Given this list of marker genes MRPL40, CAAP1, MPZL3, RFC4, HERC1, RBM18, MARK3, ATG5, SPINK2, TMEM179B (NCBI Gene Id 374395), WASHC4, CHRD, KAT5, HIRA, ZER1, SYNCRIP, HIP1, CANX, MSANTD2, ITPKC, ANKS1A, ZBTB11, BZW1, BTAF1, GRWD1, DIABLO, ELK4, HSPD1, PTRH2, INO80, THPO, ZCCHC9 (NCBI Gene Id 84240), BMP2K, KYAT1, SDF2, HMG20B, GPM6B, PPT2, GNB2, CRK, RNF44, UBE2H, CTTNBP2NL, DDX50, NSUN6, VCPIP1, ENDOV, SIKE1, MFHAS1, SYT6, CAB39, SUPT6H, TXN2, CYCS, FBXO8, ARHGEF7, TAF11, PRKACB, SPRY2, UQCRB, TRA2B, KCNN2, TIMM8A, WDR1, TTPAL, WDR48, MRRF, CAD, CEP55, VMP1, GGNBP2, HSPE1, SETX, RPS27, CNOT4, COQ8B (coenzyme Q8B), AP1M1, FOSB, CEP44, here is a description of the gene set: species: Homo sapiens from publication Xie X, Lu J, Kulbokas EJ, Golub TR, Mootha V, Lindblad-Toh K, Lander ES, Kellis M (PMID 15735639) Genes having at least one occurrence of the highly conserved motif M106 CCGNMNNTNACG in the regions spanning 4 kb centered on their transcription starting sites. The motif does not match any known transcription factor binding site. Comprehensive identification of all functional elements encoded in the human genome is a fundamental need in biomedical research. Here, we present a comparative analysis of the human, mouse, rat and dog genomes to create a systematic catalogue of common regulatory motifs in promoters and 3' untranslated regions (3' UTRs). The promoter analysis yields 174 candidate motifs, including most previously known transcription-factor binding sites and 105 new motifs. The 3'-UTR analysis yields 106 motifs likely to be involved in post-transcriptional regulation. Nearly one-half are associated with microRNAs (miRNAs), leading to the discovery of many new miRNA genes and their likely target genes. Our results suggest that previous estimates of the number of human miRNA genes were low, and that miRNAs regulate at least 20% of human genes. The overall results provide a systematic view of gene regulation in the human, which will be refined as additional mammalian genomes become available. Human Gene Set: CCGNMNNTNACG_UNKNOWN